The following is a description of a gene set: Adenocarcinoma of the intestines A malignant epithelial tumor with a glandular organization that originates in the intestines. Human Gene Set: HP_ADENOCARCINOMA_OF_THE_INTESTINES studied in species Homo sapiens, and this is the list of marker genes: HEATR3, RPS7, RPS28, MAD1L1, MLH1, RPS24, MST1 (NCBI Gene Id 4485), RPL35A, MSH2, TSR2, GPR35, SEMA4D, GREM1, GATA1, RPL31, MUTYH, RPL5, TCF4, POLE, RPL9, RPS10, RPL15, RPL18, NTHL1, RPL11, AAGAB, RPL8, RPS15A, RPS20, RPS27, RPS17, RPS19, APC (NCBI Gene Id 324), BMPR1A, RPS26, RPS29, RPL27, COL14A1, SMAD4, RPL26, RPL35, ADA2, POLD1